Given this list of marker genes ARRDC2, ACADS, SULF2, DOCK8, PDLIM3, TIMP2, ITGA1, SMYD2, VSTM4, MAN1A1, ABHD17B, NICOL1, ASGR1, TMEM140 (transmembrane protein 140), GNG12, CDC42EP5, PDE2A, ARRB2, SLC24A1, PRR5L, CDKN1A, SNCAIP, F8, TLE1 (TLE family member 1, transcriptional corepressor), LAPTM5, APBA2, MAGED4B, PKHD1L1, CD302, MID1, CDA, EDNRB, PIEZO2, PRKCZ, LGALS3, SFRP1, TRIL, INPP4B, GLIPR2, FAM107B, ATP9A, CFI, CRACR2B, DTX4, C15orf39, PTPRE, DLGAP1-AS1, SCNN1B, FAM162B, PPARGC1B, DAPK1, ST3GAL6, SCAMP5, CTTNBP2, SLC27A3, WASF3, NAV3, CARD19, CYP46A1, CMBL, TRIP6, SLC35E4, TPD52, GPR182, COL5A2, CXADR, PRKG1, PPIC, PXMP2, SH3PXD2B, ANKDD1A, MATN2, STON2, SLC7A7, TRMT9B, ITGA9, CNTNAP3B, CCL14, PLA2G4C, COL4A5, PROX1, PDPN, UGP2, BCL7C, DSE, C1QTNF4, SCGB3A1, PMP22, SNX10, BZW2, P4HA3, SCRN1, UNC5B, GLIS3, MAP3K1, GCNT2, MTSS2 (NCBI Gene Id 92154), MEDAG, UBTD1, PXDC1, SLC43A3, HOXA7, HTRA1, SMOC1, WDFY2, MAGI1, OAF, ACSL5, TXNL4B, FHL2, RAB6B, CD74, ENTREP1, FCGR2A, ARRDC4, CHCHD10, SLC45A3, MRC1, PLSCR4, RHOD, VAV3, EFEMP1, CCL21, TBX1, ODF2L, SNCB, TPBG, NTN1, MFAP4, FRZB, CAPG, TFF3, SCARA3, SUSD4 (sushi domain containing 4), LIMCH1, B3GNT7, COLEC12, GJA1, HSD3B7, NLGN4X, EEIG1, IMPDH1, SCN3A, SH3TC1, NNMT, TC2N, NR1H3, OLFML1, RELN, KCNIP1, SGK3, PLEKHA4, DOC2B, TSHZ3, ADAMTSL3, LAPTM4B, ZP2, TSPAN11, APH1B, ABHD2, TSHZ2, CRTAC1, ACKR2, PGM5, C6orf141, POLE4, STK32B, KCTD17, CYTL1, LYN, MEGF6 (NCBI Gene Id 1953), ASPH, GGT5, KLHL4, HS3ST1, PGF, PLAAT4, ANKRD6, DTX1, LRRC70, SLC43A2, NHSL3, CEP85L, VPS35L, ITSN1, PCSK6, SPHK1, SPR, ABI3BP, EMILIN1 (NCBI Gene Id 25883), HOXD8, CERS6, STAB1, GAB2, CMKLR2, CISD1, NFIA-AS2, PLIN5, CHST15, GALNT15, NR2F1, IQSEC3, LAYN, KALRN, PCLO, CTHRC1, NUPR1, SNCG, GJC2, ZFPM2, CTDSPL, DNMBP, TSHZ1, PRKAG2, SGIP1, ZNF521, EFNA5, CHRDL1, USP13, LETR1, ARFGEF2, ENOSF1, EMID1, SLCO2B1, NPNT, CDKL1, DOCK5, HAPLN3, SGCE, TRPC6, MTUS1, OLFML2A, CYP39A1, RSPH4A, SYNE1, UBAP1L, CHKA, DKK3, FLNC, DNASE2, RAB11FIP3, STOX2, SLC38A1, LAMB1, GPRIN3, RAB11FIP1, KLHL3, BMP2K, HSDL2, MMP17, P2RX4, PGAP4, TBC1D2B, IGF1 (NCBI Gene Id 3479), COQ2, EPS15, LY96 (lymphocyte antigen 96), ARFGAP1, NR2F2-AS1, WIPF1, RAB3IL1, MYO7A, SAT2, PLEKHO2, SCN3B, C20orf204, PGM1, LRIG1, SLC22A23, MPP7, MMRN1, MVP, GPRC5C (G protein-coupled receptor class C group 5 member C), DSEL, FILIP1, CCDC102B, LGMN, TTN (titin), IPO11 (importin 11), SPOCK3, HOXD9 (homeobox D9), MYO5C, FHL3, ADIRF, PDGFA, MGST1, GIMAP5, LGALS7, TMEM38B, MAGED4, CXXC5, SEMA3D, ARID5B, TMEM120A, NR2F1-AS1, BCHE, PPARG, IL7, CEACAM1, GCNT1, CALHM6, LRRN4CL, DNPH1, AFDN-DT, GAS7, PLD1, GALNT1, RAB11FIP5, HIVEP3, IGFBP5, LTBP4, DSP, PRSS23, PARD6G, NIBAN1, SLC26A4, IFT57, TGFBRAP1, MICAL2, KBTBD11, DHODH, PTX3, TNFAIP8L3, NTS, FAM174B, EPHB1, ANGPT2, THEMIS2, NKAIN4, GNB5, SNAI2, CASP4, TNFRSF11A, RPP25, PDIA5, CAMKK2, LOX, MITF (melanocyte inducing transcription factor), CLU, ASB13, CCDC80, ZDHHC14, FLRT2, SDC3, GLS, THSD7A, KIF3C, SQOR, LGALS7B, SCN9A, PDE1A, ABLIM3, SPATA6, CYP4X1, NBL1, SYNM, GLT8D2, STAB2, REEP1, MCTP1 (multiple C2 and transmembrane domain containing 1), IQCA1, EPHB2, SPRY1, RASSF9, RHOU, PLEKHG3, P3H2, APOD, SEMA3A, FRMD6, MAN2A1, SIRPA, ISLR2, KLKB1, SFXN3, LRCH2, GPM6A, SLC9A9, TM4SF18, LINC01116, OAS1, ADAMTS12 (NCBI Gene Id 81792), here is a description of the gene set: species: Homo sapiens from publication He P, Lim K, Sun D, Pett JP, Jeng Q, Polanski K, Dong Z, Bolt L, Richardson L, Mamanova L, Dabrowska M, Wilbrey-Clark A, Madissoon E, Tuong ZK, Dann E, Suo C, Goh I, Yoshida M, Nikolić MZ, Janes SM, He X, Barker RA, Teichmann SA, Marioni JC, Meyer KB, Rawlins EL (PMID 36493756) Human Gene Set: HE_LIM_SUN_FETAL_LUNG_C3_LYMPHATIC_ENDOTHELIAL_CELL Lymphatic endo